Given this list of marker genes TMPRSS6, CARD8, CAPN1, IHH, CAPN7, ADGRV1, DHH, CAPN3, NLRP1, CASP8, SHH, here is a description of the gene set: The hydrolysis of proteins into smaller polypeptides and/or amino acids by cleavage of their own peptide bonds. Human Gene Set: GOBP_SELF_PROTEOLYSIS species: Homo sapiens